Given this list of marker genes Pla2g4e, Pla2g4a (phospholipase A2, group IVA (cytosolic, calcium-dependent)), Plbd1, Pla2g15, Pla2g4b, Pla2g4c, Pla2g4f, Pla2g4d, here is a description of the gene set: Hydrolysis of LPC studied in species Mus musculus Mouse Gene Set: REACTOME_HYDROLYSIS_OF_LPC